The following is a description of a gene set: studied in species Mus musculus An axon of a hippocampal granule cell, including dentate gyrus granule cell and CA3 granule cell, characterized by expansions (mossy fiber expansions) giving the fibers a mossy appearance. These unmyelinated axons were first described by Ramon y Cajal. Mouse Gene Set: GOCC_HIPPOCAMPAL_MOSSY_FIBER, and this is the list of marker genes: Slc30a3, Map1b, Mapk8ip1, Slc4a8, Pde2a, Mical1, Tnn